Given this list of marker genes Rdh11, Esd, Adh5, Aldh1a7, Rdh12, Aldh2, Park7, Akr1a1, Adh4, Aldh1a1, here is a description of the gene set: studied in species Mus musculus Mouse Gene Set: GOBP_CELLULAR_DETOXIFICATION_OF_ALDEHYDE Any process carried out at the cellular level that reduces or removes the toxicity of an aldehyde. These may include transport of aldehydes away from sensitive areas and to compartments or complexes whose purpose is sequestration of the toxic substance.